Given this list of marker genes Fbxo21, Phactr2, Trank1, Usp12, Ist1, Bicd1, Pla2g15, Avl9, Higd1a, Iars1, Arhgap12, Dixdc1, Zmym2, Cc2d1b, Htr4, Wwp1, Klc1, Desi1 (NCBI Gene Id 28075), Hapstr1, Fasn (fatty acid synthase), Wnt7a, Crebl2, Ubn2, Aar2, Polr3f, E2f3, Zbtb34, Akap11, Kcnj2, Vegfa, Fmn2, Luzp1, Slc4a7, Itpr1, Ncs1, Spag7, Fgf9 (fibroblast growth factor 9), Hmga1, Lrrc32, Mapkap1, Prdm4, Slc20a2, Tacc1, Cert1, Sema3a, Entpd7, Clock, Epha7, Unc80 (unc-80, NALCN activator), Kif1c, Sox6, Ahcyl2, Zbtb44, Usp42, Arfgap2, Ankrd13b, Phip, Mybl1, Cpeb2, Peli3, Gpr63, Satb2, Lurap1l, Angel1, Fbln5, Rere, Trabd2b, Mfn2, Atg14, Slc25a22, Abtb2, Cnot6l, Arih1, Adgrl1, Ube4b, Ythdc1, Usp14, Capns1, Ccr2, Selenoi, Cpeb3, Amotl1, Cyp26b1, Qki, Eda, Nudt7, G0s2, Ube2q1, Tll1, Phc3, Ccnd2 (NCBI Gene Id 97325), Pnp2, Tuba4a (NCBI Gene Id 22145), Usp15, Rfc1, Adissp, Plekhm3, Ell, Chd2, Grm7, Kctd8, Raf1, Cacul1, Acvr2a, Nlrx1, Dll4, Atp7a (NCBI Gene Id 51824), Fbxw7, Cntnap1, Smad7, Ghr, Rreb1, Akt3, Btg2, Tnrc6b, Mob3b, Ccnt2, Rnf217, Cbfa2t3, Zswim3, Pth, Rasef, Idh3a, Cdk12, Armcx6 (armadillo repeat containing, X-linked 6), Bcl2, Col12a1, Abl2, Nos1, Rnf10, Pip4p1, Zbtb39, Drd1, Cacna2d1, Cops7b, Smim13, Sesn1, Ret, Mmd, Dnajc16, Dcp1a, Mlycd, Wipi2, Btrc, Ccnjl, Slit2 (slit guidance ligand 2), Lats1, Nuak2, Atxn2, Pappa, Clspn, Plxna4, Usp25, Tenm2 (teneurin transmembrane protein 2), Zfp367, Ubfd1, Onecut2, Pnoc, Ppp6c, Plxna2, Penk, Dcaf7, Mgat4a, Tbpl1, Setd3 (SET domain containing 3), Lrig1, Stxbp3, Nav1, Capn6, Nfatc3, Bcl2l2, Ints6l, Chd6, Hectd1, Prmt6, Cdc25a, Sec14l1, Seh1l, Sgk1, Aff4, Eif3a, Plpp1, Slc39a10, Myb, Arhgdia, Kdsr, Jarid2, Kif23, Rasgef1b, Kpna1, Klhl2, Cdk17, Gbp2b (NCBI Gene Id 677276), E2f7, Garem1, Sel1l3, Kbtbd2, Ash1l, Atxn7l3, Prrc2c, Plcxd2, Zfhx3, Zfp809, Pip4p2, Myt1l, Cfap45, Pafah1b1, Rbm6, Sec61a1, Ago1, Atp2b2, Atf6, Traf3, Colq, Insr, Ppm1e, Slc4a4, Rarb, Anks1, Gm12886, Helz, Cdc37l1, Ptpn3, Socs6, Cobll1, 1700025G04Rik, Ccdc85b, Sik1, Pappa2, Trp53inp2 (NCBI Gene Id 68728), Tbl1xr1, Wbp11, Kif5c, Plxnc1, Fgf7, Klc4, Pnpla6 (patatin-like phospholipase domain containing 6), Rad23b, Pik3r1, Kl, Rab11fip1, Ppp2r1b, Sez6l, Rictor, Ano3, Chpt1, Hephl1, Krtap11-1 (NCBI Gene Id 338459), Rubcnl, Phf19 (NCBI Gene Id 76981), Tmem135, Phf20, Septin2, Kif1b, Tmcc1, Nufip2 (NCBI Gene Id 78671), Ezh1, Stradb (NCBI Gene Id 28142), Dsel, Etnk1, Son, Adrb2, Kcnk10, Chac1, Cmpk1, Gm5460, Tmem178b, Ppp1r11 (protein phosphatase 1, regulatory inhibitor subunit 11), Axin2, Caprin1, Cbx6, Omg, Pdxk, Sall1, Kif5b, Akap7, Zfhx4, Krtap26-1, Rnf144b, Sptbn2, Plekhh1, Cdca4, Nectin1, Cpsf7, Ago4 (argonaute RISC catalytic subunit 4), Med1, Fermt2, Arl2 (NCBI Gene Id 80563), Kif21a, Smurf1, Ncapg2, Nup50, Rab10, Dennd10, Cd2ap, Pam, Igf2r, Crebrf, Armh4, Shoc2, Znrf2, Wnk3, Pacsin2, Slc6a11, B4galt1, Srpra, Rab9b, Pwwp2b, Rfx3, Nol4l, Ippk, Wnt3a, Lrig2, Slitrk6, Il7r (NCBI Gene Id 223338), Map2k1, N4bp1, Slc7a2, Ccdc6, Gpatch8, Eya1, Suco, Bace1, Syde2, Reck, Casr, Zfp622, Csrnp1 (NCBI Gene Id 215418), Pou2f1, Cdk5r1, Bmpr1a, Spred1, Lhx3, Sema6d, Ptprr, Sall4, Scoc, Xpo7, Erlin2, Nrn1 (NCBI Gene Id 68404, neuritin 1), Ddx3x, Cpd, Ywhah, Dclk1, Fam151b, Usp31, Il10ra, Tlk1, Spsb4, Tab3, Apln, Zcchc3, Mex3c, Chek1, Nrbp1, Ccne1 (NCBI Gene Id 12447), Zfp449, Dll1, Adamts3, Atp1b4, Nup210, Dync1li2, Nudt4, Spryd3, Tgfbr3, Man2a2, Wee1, Slc13a3 (NCBI Gene Id 114644), Lrp6, Ski, Actr2, Islr, Prkar2a, Med26, Tmem74b, here is a description of the gene set: Genes predicted to be targets of miRBase v22 microRNA mmu_miR_497a_5p in miRDB v6.0 with MirTarget v4 prediction scores > 80 (high confidence targets). from publication Chen Y, Wang X (PMID 31504780) studied in species Mus musculus Mouse Gene Set: MIR_497A_5P